Given this list of marker genes Cln3, Esyt1, Cptp, Arf1, Plekha8, here is a description of the gene set: part of: Transport of small molecules studied in species Mus musculus electronically inferred by orthology from the curated human pathway This event has been computationally inferred from an event that has been demonstrated in another species.<p>The inference is based on the homology mapping from PANTHER. Briefly, reactions for which all involved PhysicalEntities (in input, output and catalyst) have a mapped orthologue/paralogue (for complexes at least 75% of components must have a mapping) are inferred to the other species. Reactome Pathway: Glycosphingolipid transport